Given this list of marker genes IHH, SCUBE2, SHH, DHH, GPC5, ADAM17, DISP2, NOTUM, here is a description of the gene set: Release of Hh-Np from the secreting cell Human Gene Set: REACTOME_RELEASE_OF_HH_NP_FROM_THE_SECRETING_CELL studied in species Homo sapiens